The following is a description of a gene set: from publication Yevshin I, Sharipov R, Kolmykov S, Kondrakhin Y, Kolpakov F (PMID 30445619) Mouse Gene Set: SPIB_TARGET_GENES Genes containing one or more binding sites for (Spib) in their promoter regions (TSS -1000,+100 bp) as identified by GTRD version 20.06 ChIP-seq harmonization. studied in species Mus musculus, and this is the list of marker genes: Wdfy4, Gusb, Pik3cg, Lilra6, Tacc1, Snord55, Gm9968, Sp140l2, Nfkb1, Snord11, Aff3 (AF4/FMR2 family, member 3), Mir8099-1, Gm5447, Nsmaf, Igkv13-82, Cyp46a1, Eif4enif1, Alox5ap, Plxnc1, Samd9l, Ctps2, Rinl, Trim25, Elmo1 (NCBI Gene Id 320830), Cdk9, Clec12a, Gpr68, Cybc1, Fbp2, Akain1, Nek6, Serpinf1, Arhgap22, Cog8, Rassf1, Gm2182, Bcl11a, Mef2c, Pold1 (polymerase (DNA directed), delta 1, catalytic subunit), Ncf4, Arpc4, Pira12, Phf11, Ctss, Traf3ip3, Gm15628, Scrt1, 5830418P13Rik, 6820431F20Rik, Oard1, Gm16675, Chmp1b2, Exoc2, Cd53, Plekhm3, Nudt3, Rasa3, Gpr18 (NCBI Gene Id 263515), Gsto2, Fam110a, Tank, Gm19774, H2-K1 (histocompatibility 2, K1, K region), Atp9b, Tor1aip2, Gm13814, Lsp1, Tpi-rs2, Snx30, 2310010J17Rik, Pdlim2, Gid8, Nfkbid, Atic, Aldh3a2, Nup54, Patz1, Relt, Ccdc186, Pkn3, Nuggc (NCBI Gene Id 637464), Snord49a, Tor1aip1, Mir7b, Nip7, Exoc5, Cdc123, Btk, Bin2, Gm10384, Lrrk1, Rgs14, Rwdd1, Mfsd12, Wdr75, Trim7, Niban3, Mir6541, Gm10521 (predicted gene 10521), Ikbkb, Irf5, Thap6, Tada3, Mfsd4a, Cd300lf, Tlr6, Sp110-ps1, Gm10088, Ehf (ets homologous factor), Fgd2, Gm23229, Gm15897, Rbm43, Scrt2, Mir6236, F730311O21Rik, Gpd2, Anapc15, Sh3tc1, Gm22488, Bmf, 9130604C24Rik, Slc16a6, Col15a1, Dock2 (dedicator of cyto-kinesis 2), Slk, Napsa, Gprin1, Dennd4b, Sh2b3, Tsen54, Ptpn22, Glra1, Tbc1d1, Slc14a1, Tnfsf9, Gm22660, Cntn2, Cnp, Rgl2, Gm10044, H2-K2, Ptpn18, Vav1, Zfp809, Mppe1, Srsf2, Tmem229b, Glipr1, A630001G21Rik, Lmo2, Arpp19, Nlrc4 (NLR family, CARD domain containing 4), Arl10, Zfp667, Ccdc12, Atp6v0b, Hgh1, Gpatch2l, Ncf1, S100a4, Vamp1, A930029G22Rik, Cntnap5c, Zeb2os, n-R5s185 (NCBI Gene Id 115490001), Mfsd11, Ccdc92b, Gm26257, Tlr4, Slc39a13, Ercc6l, Tomm5, Polm, Slc15a3, Gm11399, Trem4, Tnni2, Btc, Gm10222, Synj1, Gm12996, Tia1, Mirt1, Gm26287, Phgdh, Arap1, 1700052H01Rik, Meis3, Nop58, Lyl1, Isg20, H2-Q6, Far1os, Elp5, Pfpl, Itgav, Vgll4, Ly86, Pld4, Gfi1b, Dusp5, H2-Q7, Orai3, H3c10, Prdx5, Dido1, Tlr9, Birc3, Vars2, Eri1, Cfp, Gm15931 (NCBI Gene Id 112136069), Rps8, Xpnpep1 (NCBI Gene Id 320447), Togaram2, Myo1g, Bcl2a1d, Gm20045, Mgat1, Trmt112, Snhg6, Grn, Picalm, Nsd2 (NCBI Gene Id 77281), Rfk, Tuba4a, Ndufb9, Pira13, Caskin2, Gm16170, Dglucy, Ebi3, Platr10, Gm26766 (NCBI Gene Id 108168238), Dynlt4, Irgm2 (immunity-related GTPase family M member 2), 2210022D18Rik (RIKEN cDNA 2210022D18 gene), Ccdc88b, Rgs19, Tatdn1, Rfx4 (NCBI Gene Id 71137), Tmem116, Lrp11, Gm16046, Tph2, Samd4, Tnfaip3, Ipo11, Kif5c, Fcgr2b, Tas2r138, 4930580E04Rik, Ms4a1, Tcirg1, C920009B18Rik, H3c6, Snord49b, Zbtb20, Nckap1l, Zkscan17, Limd2, Dapp1, Tnfrsf13b, H2-Q4, Tbc1d10b, Coa5, Ccdc86, Slc23a2, H2-DMb2, Phf14, Gm12089, Icam1, Fam168a, Tmsb4x, 1300002E11Rik, Pnrc2 (NCBI Gene Id 67799), Ssbp1, Scimp (NCBI Gene Id 547221), Slfn8, Gm26330, Esyt1, Usf1, Zcwpw2, Psmb8, Alg9, Neurod4, Kif3b, Unc50, Sec14l1, H2bc13, Dpep2, Tent5d, Ehd1, Trem6l, Laptm5, Phf12, Prr14l, Gm15564, Zeb2, Padi2, Tagap, Pgghg, Gm18733, Epn1, Cd37, Gm22107, Prkcd, Irf2, Hid1, Arhgdib, Alg13 (NCBI Gene Id 72688)